The following is a description of a gene set: Human Gene Set: HP_APLASIA_HYPOPLASIA_OF_THE_BRAINSTEM Aplasia/Hypoplasia of the brainstem studied in species Homo sapiens, and this is the list of marker genes: COL3A1, MINPP1, POMT1, NSRP1, LARGE1, VLDLR, TUBB, CEP55, WARS2, PIEZO2, PRDM13, KPNA3, PPIL1, CASK, POGZ, PYCR2, INPP5E, TUBA8, MFSD2A, TMEM67, RAC1, TMEM216, FH, SMPD4, TUBA1A, MAST1, RAB11B, PDHB, TSEN54, TSEN15, PPP1R15B, FKRP, CHMP1A, BRF1, CTNNA2, B4GAT1, RPGRIP1L, PI4K2A, TUBB2B, TUBB3, COASY, TMX2, NFIX, BLTP1, LAMB1, TMTC3, MACF1, DYNC1H1, MTRR, POMGNT1, TSEN34, MED17, PAFAH1B1, FKTN, PTCH1, ASNS, CRPPA, CSPP1, PPP2CA, TSEN2, TMEM237, NDE1, TUBB2A, POMK, PTEN, ADCY5, MYMK, MYH3, EXOC7 (exocyst complex component 7), SEPSECS, EXOC2, KIFBP, EN1, PCLO, CIT, DYNC1I2, GMPPB, TRMT10A, AHDC1, KIAA0586, POMT2, FLVCR2, DYRK1A, ADGRG1, CDC40, USP9X, ASXL1, TOE1, B3GALNT2, APC2, WDR73